Given this list of marker genes Pcgf2, Phc1, Eed, Rnf2, Ring1, Suz12, here is a description of the gene set: studied in species Mus musculus Chromatin that is part of a sex chromosome. Mouse Gene Set: GOCC_SEX_CHROMATIN